Given this list of marker genes Wnt4, Pdgfb, Calb1, Lamb2, Hes5 (NCBI Gene Id 15208), Pkd1, Stat1, Sox9, Pkd2, Acat1, Hes1, Fat4, Pou3f3, Umod, Osr1, Lif, Wnt7b, Wwtr1 (NCBI Gene Id 97064), Mtss1, Slc22a6, Slc22a1, Cxcr2, Aqp1, Gdf6, Adipoq, Nphs2, Pax2, Lgr4, Pax8, Wnt9b, Sox8, Yap1, here is a description of the gene set: studied in species Mus musculus The process whose specific outcome is the progression of an epithelium in the metanephros over time, from its formation to the mature structure. An epithelium is a tissue that covers the internal or external surfaces of an anatomical structure. Mouse Gene Set: GOBP_METANEPHRIC_EPITHELIUM_DEVELOPMENT